The following is a description of a gene set: Mouse Gene Set: GOBP_POSITIVE_REGULATION_OF_CYTOSOLIC_CALCIUM_ION_CONCENTRATION species: Mus musculus Any process that increases the concentration of calcium ions in the cytosol., and this is the list of marker genes: Akap5, Cacna1d, Trpc6 (transient receptor potential cation channel, subfamily C, member 6), Fpr2, Hrh4, Nptn, Kng2, Ptger4, Trhr, Cxcr1, Ednrb, Ryr2 (NCBI Gene Id 77553), Pmch, Ric3, Gpr6, Slc8a3, Gpr35, Tac1, Npff, Epo, Gja1, Cxcl2, P2rx7, Ccr1, Il1b, Ccr9, Agtr1b, Abl1, Tac4, Ffar1, Bmp4, Gpr33, Cav3, Ffar4, Trpm4, Ccl3, Galr1, Lrp1, Tacr1 (NCBI Gene Id 21336, tachykinin receptor 1), Itgav (NCBI Gene Id 76358), Cd36, Sppl3, Crhr1, Adra1b, Bcl2, Plcz1, Cx3cr1, Ackr4, Itpr1, Pkd2, Cacna1c, Ccr5, Cxcr2, Eif5a, Ccrl2, Ccl1, Prkg1, Plcg2 (phospholipase C, gamma 2), Cxcr6, Gng3, Cacna1g, Cd55b, Mchr1, Lrp6, Ccr6 (C-C motif chemokine receptor 6), Cdk5, Gimap5, Fpr3 (NCBI Gene Id 224542, formyl peptide receptor 3), Pla2g6, Cav1, Cd38, C5ar2, Fpr1, Slc8a1, Pik3cg, Ednra, Ptger2, Swap70, Glp1r, Lhcgr, Ackr2, Avpr1a, Gper1, Gck, Adcyap1, F2r, Il2 (interleukin 2), P2ry1, Ptgfr, Nmu, Bdkrb2, Adra1d, Selenot, Nmb, Cckbr, Hrh3, Avp, Cxcl3, Oga, Gata2, Tbxa2r, Adcy8, Oprm1, Ptk2b, Jph2, Ccr7, Npy2r, Fpr-rs6, Ptgir, Gnat2, P2ry2, Ccl28, Cckar, Fpr-rs7, Ccr8, Gimap3, Asph, Chrna9, Cxcl1, Ptger3, Cmklr1, Dlg4, Cxcr5, Chrna10 (cholinergic receptor, nicotinic, alpha polypeptide 10), Tmbim6, C3ar1, Pth1r, Trpc2, Jak3, Jak2, Cib2, Cacnb3, Cxcr3, Ackr3, Fkbp1b, Adra1a, Agt, Abl2, Xcr1, Gna13 (NCBI Gene Id 14674), Adm, Cxcl17, Bax (NCBI Gene Id 12028), Pkd1, Htr2a, Fpr-rs3, Calcr, Cxcl13, Slc8a2, Hcrt, Cacna2d1, Ptger1, Trpv5, Galr2, Trpc3, Adcyap1r1, Ccr1l1, Kng1, Cacna1a, Ccr10, Trpc5, Cd4, Cd52, Gipr, Uts2, Edn1, Gata1, Trpv1, Agtr1a, Oxt, Cd24a, Ccr4, Hmgb1, Grin1, Cacna1i, Kiss1, Trpv4, C5ar1, Uts2r, Pml, Gnb1, C1qtnf1, Adcy5, Ghrl, Ccr3, Ptgdr, Cxcr4, Kdr (NCBI Gene Id 269657), Fpr-rs4, Itpr3, Fzd2, F2rl1, Cd55, Ccr2, Esr1, P2rx4, Ghrh, Epor, Oxtr, Bak1